The following is a description of a gene set: Any process that activates or increases the frequency, rate or extent of osteoblast differentiation. studied in species Homo sapiens Human Gene Set: GOBP_POSITIVE_REGULATION_OF_OSTEOBLAST_DIFFERENTIATION, and this is the list of marker genes: ACVR2B, MIR210, NPPC, BMP6, BMPR1B, FBXO5, LRP5 (LDL receptor related protein 5), TMEM119, SMAD1, JUND, TAOK3, LTF, CTNNBIP1, GLI3, VEGFA, SFRP2 (NCBI Gene Id 6423), BMPR1A, ILK, MIR548D1, ACVR2A, MEF2C, PPP3CA, SUCO, NELL1, WNT3, ZHX3, DNAI3, FGF2, CTNNB1, TP63, MIR20B, YAP1, CCN1, IL6R, IGF1, MIR21, GDF10, MSX2, FBN2, CEBPA, BMP2, MIR29B1 (NCBI Gene Id 407024), PRKD1, DDR2, WWTR1, WNT4, NPNT, TENT5A, FERMT2 (NCBI Gene Id 10979), MIR200C, IFITM1, WNT7B, PRMT3, IL6ST (interleukin 6 cytokine family signal transducer), ATRAID, BMP4, LRP3, MIR3648-1, CTHRC1, JAG1, MIR27A, CCN4, SOX11, HGF, FFAR4, CEBPD, MIR20A, SCUBE3, FZD1, WNT10B, IL6, SMAD5, CLIC1 (chloride intracellular channel 1), CEBPB, GDPD2, ACVR1 (NCBI Gene Id 90), BMPR2, FAM20C, RUNX2 (RUNX family transcription factor 2), BMP7 (NCBI Gene Id 655)